The following is a description of a gene set: Human Gene Set: GSE21063_CTRL_VS_ANTI_IGM_STIM_BCELL_8H_UP from publication Bhattacharyya S, Deb J, Patra AK, Thuy Pham DA, Chen W, Vaeth M, Berberich-Siebelt F, Klein-Hessling S, Lamperti ED, Reifenberg K, Jellusova J, Schweizer A, Nitschke L, Leich E, Rosenwald A, Brunner C, Engelmann S, Bommhardt U, Avots A, Müller MR, Kondo E, Serfling E (PMID 21464221) Triggering of B cell receptors (BCR) induces a massive synthesis of NFATc1 in splenic B cells. By inactivating the Nfatc1 gene and re-expressing NFATc1 we show that NFATc1 levels are critical for the survival of splenic B cells upon BCR stimulation. NFATc1 ablation led to decreased BCR-induced Ca++ flux and proliferation of splenic B cells, increased apoptosis and suppressed germinal centre formation and immunoglobulin class switch by T cell-independent antigens. By controlling IL-10 synthesis in B cells, NFATc1 supported the proliferation and IL-2 synthesis of T cells in vitro and appeared to contribute to the mild clinical course of Experimental Autoimmune Encephalomyelitis in mice bearing NFATc1-/- B cells. These data indicate NFATc1 as a key factor controlling B cell function. species: Homo sapiens Genes up-regulated in B lymphocytes: control versus stimulated by anti-IgM for 8h., and this is the list of marker genes: LY6D, RUFY4, ABI2, HIVEP3, NR4A1, SAMSN1, ASTL, TMEM64, LMLN (leishmanolysin like peptidase), KRAS, FILIP1L, HRH2, CD300A, PARP14, SH3PXD2B, DCAF12L1 (NCBI Gene Id 139170), SPATS2, TNFAIP3, KMO, ME2, SCRN2, RETREG1, TSPYL2, EPCAM, CD274, HERC3, PLB1, IL12B, ENAM, TNIP2, PPP1R15A, GADD45B, MIR30D, RIGI, PTPN21, SRFBP1, TM6SF2, GPR174, TRIM46, ADRB2, LY6E, ERN1, FAM124B, SESN3, PCYT1A, RFX4, PTGER4, CALHM6, PAQR6, IRF4, EGR2, CDK5R1, BIRC3, ABCB9, DCBLD2, NAV1, PROKR1, TNFRSF25, PPM1L, TNNT2, BST1, GPR183, MGAT3, CD5, PLK2, SEPTIN11 (NCBI Gene Id 55752), LAMA1, RCL1, EGLN3, KBTBD11, PRR9, TNFSF10, ITIH5, CD177, ISG15, GRIK1, AJAP1, NR4A3, TRPV4, HMGN3, DAB2, ADAM15, ATCAY, SH3BP2, NFKB1, GAS8 (NCBI Gene Id 2622), PDZD2, WLS, STAP1, BTLA, COBLL1 (cordon-bleu WH2 repeat protein like 1), THRB, KRTAP4-1, SEMA4G, RELB, NAB1, PPP1R3D, NT5C1A, CLIC4, TIFAB (TIFA inhibitor), ANGPT1, CYTIP, ETNK1 (ethanolamine kinase 1), ZFP36, ICAM1, TRAM1, NFKBIZ, LRRC49, AP1S2, TRIM66, ITM2A, TMEM63A, LHFPL2, BRSK2, NDRG1 (NCBI Gene Id 7998), VMO1, CHL1, GPR146, DNAJB2, TRIB1, LYNX1, ARAP2, NFKBIA, HDAC5, CD300LF, NME1, RFX5, LARS1, NFKB2, PDZD7, B4GALNT3, NCOA3, SPRY4, MED22, ETV5, ANK1, TNS3, CD6, PLAUR, TSC22D1, RNF122, EEIG2 (NCBI Gene Id 284611), CAMK2D, MYO10, CHSY1, P2RX7, IL17RB (NCBI Gene Id 55540), SORCS1, MSL3B, ZBP1, REG4, MALT1, FFAR3